The following is a description of a gene set: Human Gene Set: HP_ABNORMALITY_OF_THE_MALE_GENITALIA Abnormality of the male genitalia studied in species Homo sapiens Abnormality of the male genital system., and this is the list of marker genes: SEMA3E, HNRNPH1, PTDSS1, TCTN3, NKX2-6, SCUBE3, RPS26, DHH, NFIX, RPS17, AHDC1, ACBD6, CHRM3, MLXIPL, ARL6, DUSP6, CLDN2, ECE1, BRAF, CAMK2A, MIF, EIF4A2, CHST14, ANAPC1, POLR3K, POMGNT2, FLT4, BRWD3, NAF1, TRIP13, UPF3B, BBS1 (NCBI Gene Id 79702), ZBTB20, RNF212, MED12L, MRE11, BRF1, IGKC, H4C11, BCOR, ERCC3, PLCB4 (phospholipase C beta 4), YWHAE, GPC3, TNRC6B, SMG8, SLC32A1, RNF113A, MTMR14, FANCM, NHLH2 (NCBI Gene Id 90888), RNU7-1, RNU12, PTEN, H4C5 (H4 clustered histone 5), RRAS2, PPP1R15B, PAX6, HID1, POLR1B, WDR37, EPHB2, FOXE1, CEP152, PIEZO2, KRT5, DKC1, STAT6, PAFAH1B1, PLAG1, HNRNPK (heterogeneous nuclear ribonucleoprotein K), WBP4, EBF3, NEB, EDNRA, IL17RD (NCBI Gene Id 54756), SPECC1L, BUD23, PUF60, MEG3, MTM1, PEX19, SMC3, NAA10, ALX4, WNT3, FGFR1, GNRHR, PRKCZ, VAC14, LHB, KMT2E, CHD7, SDHC, PAX7, NEUROD2, CLCN4, HUWE1, SLC26A9, FRAS1, DLL3, CYP11A1, WDR62, GATA1, TAPT1, RXYLT1, DNAJC30, TSPYL1, SCYL2, PNLDC1, RPS15A, AAGAB, TP63, EP300, PRIM1, ESAM, ADAT3, HEATR3, CPLANE1, DLL1, PIGN, NECTIN1, CHEK2, GFM2, GNAO1, CDC42, HPSE2, EMG1, CHD4, GALT, MAD2L2, PEX26, UPB1, KIF7, GRIN2B, ATAD3A, FAT4, MBD5, OPHN1, FBLN1, FZD2, TLR4, TRPM3, CCDC32, JAM3, HYMAI, TARS1, SC5D, AMHR2, RAC1, ABL1, DSE, POLR1A, CDC73, RTL1, TBL1XR1, SOX18, SETD1A, DPP9, FILIP1, TASP1, TGIF1, BMP2, KMT2D, TERC, RPL35A, CLCN3, SMARCB1, SLC18A3, B4GAT1, DYNC2I1, FLG, PPP1R12A, FIG4, STT3A, KLHL41, LARP7, SYNGAP1, VHL, SOHLH1, ARX, MAB21L1, SMARCD1, NFIB, LAMA5, SLC16A2, NDP, TXNDC15, RTEL1, TEX11, EDEM3, CILK1, PRDM13, HSD3B2, SRD5A2, UQCC2, KLHL10, SKI, KCNAB2, STRA6, SCN1B, HCCS, CWC27, UBE4B, HPRT1, MAF, IL12A-AS1, CEP41, DNA2, NSD2, COG5, AMH, PIEZO1, BIN1, CDKL5, CCDC141, NBN, CEP120, ZFPM2, ARID1A, AARS1, SOX11, WDPCP, BBS7, SLC30A7 (solute carrier family 30 member 7), HS6ST1, PYCR1, AKT1, HYLS1, TINF2, ATP6V1E1, XRCC4, MMP23B (matrix metallopeptidase 23B), KAT6B, TSHB, RPS28, GBA2, KMT5B, MDM2, CDKN2A, NHP2, BBS2, ARL6IP6, LMNA, HIRA, RAC3, ADAR, DAG1, TRRAP, TBX22, DICER1, COL14A1, MYOD1, FANCC, TRIM32, NPM1, THSD1, RNF43, RAB3GAP2, DPH2, MAX, GAS1, AUTS2, EVC2, CFTR, SOS1, CLP1, ERCC4, GJA5, SCN2A (sodium voltage-gated channel alpha subunit 2), EIF4H, CDKN1C, FKBP6, COL3A1, DYNC2LI1, RERE, JMJD1C, PEX3, ANKLE2, UBR7, PRKDC, LZTFL1, IRF6, EHMT1, PIGP, RYR1, DYNC2H1, WDR11 (NCBI Gene Id 79207), CHRNG, ARCN1, PSMD12, UBE2T, CCDC8, KEAP1, GATAD2B, HEPACAM, COG1, KLF1, CLIC2, DYRK1A, RPL18, FOXF1, NDUFS4, OFD1, SLC39A4, MED13L, KCNQ1, GJB3, CDH11, FANCA (FA complementation group A), MAPK1, DAZ1, KDM6A, BRIP1, CYP21A2, GK, PTPN11, BRD4, SNRPN, KCNN4, LIG4, DCAF17, LMBR1, FBXO11, ORC6, TUBB, PWRN1, JAG1, EIF5A, VANGL1, TBCD, OTUD6B, FBXL4, TOGARAM1, ACTG2, MCM8, WT1, BRCA1, PIGA, MYMX, VPS13B, HHAT, BLTP1, FGFR3, ASXL3, NDNF, BAZ1B, BBS9, PAICS, PRTN3, DACT1, RPL5, WWOX, TACR3, ANOS1, PWAR1, SDHB, STAT4, DMXL2, IFT80, SLC34A2, RSPO2, DHCR24, DNMT3A, CD96, CBL, KDM5C, SMO, DOK7, PROKR2 (prokineticin receptor 2), FOXC1, NF1, SIM1, FBXW7, ZSWIM6, NOTCH3, USP7, RPL11, ERCC6, FTO, AKR1C4, C4A, SIX6, CCBE1 (NCBI Gene Id 147372), MAP3K7, DMPK, INSR, POU1F1, UFD1, RPL35, CTLA4, RIT1, KRAS, PEX11B, NODAL, TFAP2A, EZH2, DAZ2, DCTN4, NKX2-1, STT3B, NDUFB11, NDUFA8, ZMYND15, OTUD5, UBE2A, CSPP1, MAMLD1, NOTCH2, AXL, TWIST1, SPRED1, LFNG, DAZ4, RBBP8, SRA1, SDHD, TIAM1, POU6F2, BBS12, HMOX1, FANCE, ALDH1A2, GTF2E2, TP53, ODC1, NKX2-5, GSC, INSL3, GRIA2, TNFRSF1A, PIGG, FERMT1, ARVCF, FSHB (NCBI Gene Id 2488), SRRM2, IL12A, CBX2, RPL10, MED11, RNASEH2C, TTC5, FGFRL1, TAF4B (TATA-box binding protein associated factor 4b), NNT, FREM2, PBX1, DDB2, NEXMIF, WASHC5, IFT172, TGFB1, TERT, NELFA, MINPP1, LRPPRC, SCAPER, POMT2, SPRED2, ZSWIM7, SHOC2, AEBP1, HOXC13, PIGL, HDAC8, SMARCAL1, LETM1, IER3IP1, IGHG2, HOXD13 (homeobox D13), SDCCAG8, GPC4, KISS1, DTYMK, MOV10L1, B9D2, CDKN1B, RPL27, COX7B, KLHL15, ERCC8, EIF2S3, CARS1, PLVAP, MPLKIP, DHDDS (NCBI Gene Id 79947), SGPL1, SLC25A24, H1-4, MYT1L, CT55, NEK1, SNORD115-1, HDAC4, KCNH1, UBR1, APC2, TPM2, ACTA2, ADNP, MEIOB, MKKS, ADA2, DCX, TMEM237, KIFBP, DHODH, MAD1L1, LMX1B, CTBP1, SCLT1, BBIP1, PDE11A, BMP6, PPP1CB, FLNB, MAGEL2, CYP11B1, CCDC22, TRIM8, XPC, RAD51C, UBA1, PRKACA, BRCA2, SERPINA1, LRIG2, GSTM3, PRRX1, TMEM231, CYP17A1, FDFT1 (farnesyl-diphosphate farnesyltransferase 1), DPAGT1, LHCGR, ATP6V1A, PSMB10, STK11, CDK8, FAS, IFIH1, TCTN2, CLCA4, SOX10, PDE6D, CDC45, SOX5, ERCC1, AGA, MDFIC, KCNJ6, OCA2, CTCF (CCCTC-binding factor, NCBI Gene Id 10664), CKAP2L, PROK2, CITED2, ERAP1, PACS1, TMEM63A, HIBCH, DCC, TDRD9, RASA2, LSS, HESX1, CREBBP, GTF2IRD2, USP26, PHGDH, TAF4, RNU4ATAC, ATN1, NSD1, TMEM270, FLNA, SYCE1, CDT1, STS, FGF17, EBP, NTHL1, ZEB2, LHX4, MSH5, IL23R, ATP6AP2, PTPRF, NONO, TTC8, GATA5, KLLN, DIS3L2, MEGF8, PACS2, CTU2, TCTN1, DNM2, XRCC2, POFUT1, RPL15, MECP2, MCM5, ARNT2, PHF8, WDR35, MYH11, MED25, CHRNA3, PITX2, CUX1, PPFIBP1, ASH1L, FANCI, MKS1, DPYSL5 (dihydropyrimidinase like 5), SIK1, RIPK4, CASZ1, CC2D2A, MCTP2, POLG, CTC1, RNF135, KDM5B, PEX12, HS2ST1, PEX13, NDN, INPP5E, KCNQ1OT1, FARSB, IRX5, SLC29A3, AFF4, ZIC2, TONSL, H4C9, PIK3CA, HLA-DPB1, DDX59, LZTR1, CEP19, FOCAD, TGDS, GDF1, FKRP (fukutin related protein), BDNF (NCBI Gene Id 627), TBCK, MRAS, DHCR7, IL1RAPL1, TAF6, RARB, AKR1C2, GLI3 (NCBI Gene Id 2737), ZMPSTE24, PRKAR1A, EED, ZNF462, GRB10, KDR, TCF12, AR, WRAP53, DAZ3, GNAS, KDM6B, FGF8, SLC25A22, UNG, LEPR, TEX15, LEP, USP9Y, MAB21L2, SMOC1, NRAS, NPHP1, TAC3, SETD5, RSPO1, GREM1, MC2R, SLC35D1, PRMT7, ATR, RTTN, EFNB1, CLMP, SIX3, POLE, WNT7B, CEP112, KISS1R, MUSK, SLC26A2, KDSR, WFS1, PROP1, SOS2, USP9X, B3GALNT2, RPS27, ADARB1, FARS2, RPL9, CPE, OTX2, RAB3GAP1, VPS50, ABCB7, KAT5, WNT5A, TBX1, RAB23, UBAC2, DGCR2, FKTN, CCDC28B, MADD, NIPBL, POU3F3, VPS37D, GJB4, MBTPS2, XPA, SYNE1, SEC23B, BBS5, TYMS, STAG1, FMR1, SUZ12, SYCP3, GCLC, HSPG2, RAD51D, SLC11A1, GPR161, SRCAP, POMGNT1, GDF6, GJA1, TWIST2, RPS29, ATM, BUB1B, HBA1, PHF21A, RAB18, PEX10, SOX2, GLI1, CUL7 (NCBI Gene Id 9820), GNA11, PEX5, ELN, LIMK1, PSPH, ZNF699, MYLK, BRCC3, ALG8, ROBO1, SLC9A3, BBS10, TMEM94, SHH, SMARCA2, GTF2IRD1, NPAP1, XYLT2, BMP4, MYRF, BTK, OBSL1 (NCBI Gene Id 731094), RRAS, METTL23, PCNT, TOPORS, PSMC1, RLIM, GH1, LHX1, SPTBN1, GMNN, MRAP, OCRL, GRM7, CLIP2, DYNC2I2, HLA-DPA1, BMPR1A, INTU, POLR3A, ORC4, ITPR1, TBL2, TEX14, RIPPLY2, LARGE1, GRIP1, POLR1C, MAPRE2, FANCD2, PIK3C2A, PARN, NCF1, NSMF, BBS4, FAM149B1, PNPLA6, MXI1, PDE4D, RNASEH2B, NAB2, SMCHD1, IGF2, NDUFB7, FEZF1, IFT27, FANCF, RPGRIP1L, RPL31, DVL1, NR5A1, SIAH1, SMARCE1, BICRA, RFWD3, SLC19A2, HMGA2, KMT2A, FANCB (FA complementation group B), TSPY1, CASK (calcium/calmodulin dependent serine protein kinase), FGD1, CENPT, TMEM70, WNT4, RBM10, POLA1, LAS1L, MKRN3, CDCA7, TOE1, HES7, DPF2, MAP2K1, CFAP418, KANSL1, DDX3Y, NANOS1, TREX1, POMT1, ISL1, LONP1, PRKACB, RORA (RAR related orphan receptor A), EVC, STAR, GLE1, REST, PTCH1, DMRT1, GABRD, CUL4B, ATRX, COL4A1 (NCBI Gene Id 1282), CDC42BPB, POLR1D, ZDHHC9, RREB1, STX1A, MID1, RFX7, TMEM216, POGLUT1, PQBP1, ACTA1, SAMD9, SPEN, TXNRD2, THOC6, SKIC3, TCF4, ZPR1, RPS24, ERCC5, RIN2 (NCBI Gene Id 54453), SUFU, ANKRD11, CHD8, FBXO43, TMEM67, KATNIP, RAF1, COMT, DNAJC21, H19, NR0B1, KAT6A, NXN, SIN3A, CPLX1, ZMYM3, SLC31A1, STXBP1, LSM11, PHACTR1, INPPL1 (inositol polyphosphate phosphatase like 1), SUCLG1, SOX4, ESCO2, LYN, CHD6, DGCR8, GP1BB, ALMS1, CEACAM6, ALKBH8, FLRT3, ANGPT2, CDH2, SMAD4, GHR, POR, GLYCTK, EXT2, MYF6, DDX3X, IFT74, PDHA2, RPL8, HBA2, KDM1A, PHIP, FGF10, PIGQ, GTF2H5, ADGRG2, SMARCA4, PEX6, MYMK, GATA4, PEX1, RPS7, KLF6, EPG5, SMARCC2 (SWI/SNF related, matrix associated, actin dependent regulator of chromatin subfamily c member 2), DCHS1, RAD21, SEC23A, CDC6, HFE, STAG3, SATB2, FUZ, WNT7A, SPRY4, CATIP, CCDC34, MASP1, PTPN22, DHX37, GTF2I, SNORD116-1, EWSR1, IGBP1, ARMC9, MTOR (mechanistic target of rapamycin kinase), B4GALT7, VEGFC, MEFV, PDPN, PALB2, GNB2, GRIN1, TMEM107, CYB5A, CEP290, CCR1, TBCE, HNF1B, RPGRIP1, TRIM28, KIAA0753, RECQL4, IL10, SETBP1 (NCBI Gene Id 284262), WNK3, WRN (NCBI Gene Id 7486), TBX15, ALK, MAP2K2, SEC24C, FANCG (NCBI Gene Id 82603), B9D1, RBMY1A1, STAC3, COLEC11, NDUFA6, METTL27 (NCBI Gene Id 155368), RPS20, IFNGR1, GRIA3, KLHL40, HRAS, NUP88, NKAP, MED12, LMOD3, NOP10, KIAA0586, ORC1, ADAMTS3, ESS2, SPAG17, HGD, OGT, USB1, MECOM, SHOC1, DVL3, NALCN, CTDP1, CRIPTO, DNAJC19, SLX4, PNKP, PTRH2, KCNA1, COLEC10, FBN1, BLM, ADAMTS15, HSD17B3, SEMA3A, GPC6, RAD51, SALL1, ANK1, DNHD1, MYH3, KLRC4, ALG12 (ALG12 alpha-1,6-mannosyltransferase), POMK, SSR4, ACTB, DISP1, MAP3K1, USF3, AP1S2, THOC2, SLC6A14, NEDD4L, C2CD3, TERB1, G6PC3, PEX14, DLX4, PRPS1, PRDM16, GATA6 (NCBI Gene Id 2627), ARID1B, HERC1, PIGS, SLC25A10, RBMX, FLI1, DLK1, ZFHX3, PORCN, RPL10L, TERB2, MYL11, TMCO1, FGFR2, POLD1, TSR2, LMNB2, DGCR6, PLAGL1, RPL26, ALDH18A1, GJC2, LMOD1 (leiomodin 1), ARID2, MOGS, CCDC174, APC, HNRNPR, TUBA1A, PSMB8, TRIP4, PSENEN, ZFX, SPATA22, PEX2, SRY, YY1, LUZP1, RPS19 (ribosomal protein S19), ERCC2, SMC1A, POGZ, SOX9, DEPDC5, ZMIZ1 (NCBI Gene Id 57178), FANCL, TBX4, FXR1, FOXA2, PAX2, NSUN2, SOX3 (SRY-box transcription factor 3), TBX3, DNAH10, CRPPA, PUM1, PTCH2, CEACAM3, RNASEH2A, PEX16, BARD1, KIF21A, VAMP7, SMS, RAD50, KDM3B, PMM2, GLI2, HLA-B, MRPS28, ABCD4, RAPSN, FAM111A, RFC2, SAMHD1 (SAM and HD domain containing deoxynucleoside triphosphate triphosphohydrolase 1), PHF6, HERC2, DDX6, ROR2, VPS35L (VPS35 endosomal protein sorting factor like), GMPPB, RNASEL, ERMARD, CCND1, TCOF1, MESP2, FOXH1 (forkhead box H1), CDON, B3GLCT, ZMYM2, RPS10, GNRH1, TBC1D20, ATP6V0A2, CAMSAP1, HOXA13, CYP19A1